The following is a description of a gene set: studied in species Homo sapiens Genes upregulated in subsets of cells of a given type within various tumors from publication Gavish A, Tyler M, Greenwald AC, Hoefflin R, Simkin D, Tschernichovsky R, Galili Darnell N, Somech E, Barbolin C, Antman T, Kovarsky D, Barrett T, Gonzalez Castro LN, Halder D, Chanoch-Myers R, Laffy J, Mints M, Wider A, Tal R, Spitzer A, Hara T, Raitses-Gurevich M, Stossel C, Golan T, Tirosh A, Suvà ML, Puram SV, Tirosh I (PMID 37258682) In this study, an extensive analysis was conducted to define meta-programs (MPs) capturing intra-tumor heterogeneity across a spectrum of tumor types. The approach utilized non-negative matrix factorization (NMF) to analyze each cell type separately within individual tumor samples. This involved the analysis of malignant cells, macrophages, fibroblasts, endothelial cells, epithelial cells, T-cells, and B-cells. NMF was executed with varying parameter values (K=4, 5, 6, 7, 8, 9), thereby generating 39 programs for each cell type per sample. Each NMF program was summarized by the top genes based on NMF coefficients.\nRobust MPs were then delineated for each cell type using a set of stringent criteria, including recurrence within the same tumor, similarity to programs in other tumors, and non-redundancy within a tumor. Subsequently, these robust NMF programs were clustered (per cell type) based on Jaccard similarity, leading to the identification of MPs associated with each cell type.\nTo enhance the quality of the MPs, a refinement steps were undertaken, involving the removal of MPs suspected of reflecting low-quality data (with an overrepresentation of ribosomal proteins or mitochondrial-encoded genes), single-study inclusion, or similarity to miss-annotated cell types. Human Gene Set: GAVISH_3CA_METAPROGRAM_FIBROBLASTS_CAF_9, and this is the list of marker genes: C11orf96, THBS1, SPRY2, AKR1C1, MT1A, SLC4A7, SOD2, PTGS2, VASN, MIR4435-2HG, VEGFA, CXCL3, HMOX1, MYC, PHLDA1, ANXA1, TM4SF1, DDX21, SPSB1, KCNE4, CREM, ITPRIP, APOD, CCL2, TXNRD1, MAP1B, UGDH, IL6, EMP1, GPRC5A, HSPA5 (heat shock protein family A (Hsp70) member 5), TXN, NR3C1, SERPINE1, IER3, FOSL1, CYTOR, CTSL, LIF, FTH1, TNFRSF12A, IGFBP7, HMGA1, GEM, THBS2, THAP2, INHBA (NCBI Gene Id 3624), PTX3, IL1R1, CD59